The following is a description of a gene set: species: Mus musculus Mouse Gene Set: chr1H3, and this is the list of marker genes: Ifi203, Fcgr4, 4933439K11Rik, Gm26077, Ifi213, Apcs, Olfr1566-ps1, Or10aa3, Or10j3b, Gm18445, Ifi207, Or10j28-ps1, Vsig8, Or6k6, Dusp12, Fh1, Or10aa1, Or10x1, Usp21, Or10j5, 3110045C21Rik, Dedd, Tomm40l, Cfap126, Fcgr3, Copa, Or6p1, Atp1a2, Ddr2, Gm37125, Tagln2, Ndufs2, Slamf9, Casq1, Nit1, Uhmk1, Alyref2, Olfml2b, Gm7804, Or10x4, Or10aa4-ps1, Mndal (NCBI Gene Id 192690), Gm18752, Mptx1, 9430083B18Rik, Gm7871, Gm24817, Klhdc9, Or10j7, Or10j27, Gm6345, Hsd17b7, Or6k4, Gm25151, Or6n2, Gm25560, Tma7-ps, Ifi211, Cd48, B930036N10Rik, Kmo, Pigm, Ifi204, Spata46, Slamf7 (SLAM family member 7), Nhlh1, Tstd1, Gm20045, Ifi209, Sh2d1b2, Slamf1, Or10j3, Ly9, Fcrl6, Grem2, Or6y1, Ackr1, Nos1ap, Atp1a4, Or6k8-ps1, Or6n1, Cadm3, Opn3, Slamf6, Nectin4, Chml, Ncstn, Or6h1-ps1, Fcrlb, Cd84, Pex19, Or6k14, A630035G10Rik, Adamts4, Sh2d1b1, Gm37065, Gm36307, Ifi206, F11r, Aim2, Kcnj9, Igsf9, Ufc1, Gm17224, Rgs7, Kcnj10, Gm2710, Rpl27-ps1, Dcaf8, Or10f1-ps1, Atf6, Vangl2, Fcgr2b, Ifi205, Sdhc, Ifi208, Ifi202b, Cfap45, Pcp4l1, Wdr64, Mpz, Pfdn2, Mptx2, Apoa2, Arhgap30, Dusp23, Fmn2, Gm37450, Ifi203-ps, Fcer1g, Gm10521, Pea15a, Itln1, Slamf8, Gm9929, Gm38051, Igsf8, Usf1, Gm26110, Fcer1a, Gm7897, Ifi214, Gm7694, Fcrla, Or6k2, Crp, Uap1, Or10l1-ps1, Spta1, B4galt3, Ppox, Gm7299, Mir7683, Gm10171 (NCBI Gene Id 100041219), Or10z1, Cd244a, Or10j2, Gm19030, Nr1i3, Or6k3, Gm2962, 5730408A14Rik